The following is a description of a gene set: from publication Chen Y, Wang X (PMID 31504780) Genes predicted to be targets of miRBase v22 microRNA mmu_miR_1a_3p in miRDB v6.0 with MirTarget v4 prediction scores > 80 (high confidence targets). Mouse Gene Set: MIR_1A_3P studied in species Mus musculus, and this is the list of marker genes: Msantd2, Actb, 9230112D13Rik, Sprn, Fnip2, Arf3 (NCBI Gene Id 78763), Ccdc166, D6Wsu163e, Cnn3, Hspd1, Josd1, Eml3, Miga2, Kalrn, Fam168a, Peak1, Tpm4 (tropomyosin 4), Prlr, Lrrc8a, Hmcn1, Ywhaz, Vamp2, Pde7a, Tpm3 (NCBI Gene Id 59069), Cndp1, Rrm1, Utrn, Alkal2, Sec22b, Tmem178, Klf4, Pax3, Phax, Hycc1, Srsf9, Ankrd29 (NCBI Gene Id 225187), Glce (glucuronyl C5-epimerase), Zc3h7b, Map1a, Nfatc3, Cdk14, Ank3, Frs2, Smim14, Zfp40, Mon2, Tmcc1, Phyhip, Azin1, Ncoa1, Cask, Sec61a1, E2f5, Suz12, Rabgap1l, Ust, Cd2ap, Meox2, Lyz3, Nrp1, Smarcb1, Nxt2, Snai2, Kat6a, Zfp740, Bdnf, Kmt2e, Tmsb4x, Slc37a3, Atp6v1a, Rfesd, Xpo6, Cited2, Clock, Tnpo2, Ube4a, Wnt3, Rnf138, Kank4 (NCBI Gene Id 242553), Ubr5, Adprm, Ptpn14, Ttc7b, Slc29a3, Pax7, Sox17, Raver2, Ywhab, Gnpda2, Mex3c, Map4k3, Arap2, Helz2, Hnrnpu, Clcn3, Zfp661, Nxph2, Gclc, Serpinf1, Arf4, Ncl, Setbp1, Cap1, Sec63, Bach2, Arcn1, Cfap47, Ip6k2, Slc25a22, Jade3, Igf1 (insulin-like growth factor 1), Mctp1, Kcnd3, Foxp1, Sash1, Bsn, Zfp280d, Cav2, Ube2h, Tars2, Adgra3, Cped1, Ms4a7, 1700066M21Rik, Chsy1, Eva1a, Pip4p1, Nedd9, Mapkbp1, Ppp4r2, Adpgk, Mmd, Hacd3, Pirt, Elf1, Matr3, Col25a1, Cebpz, Ppib, Creb5, Syt1, Lasp1, Ets1, Esp34, Spred1, Mtx1, Edn1, Gja1, Ss18, Rictor, Stard7, Sema6d, Nol4l, Frmd3, Wnk3, Hmgn1, Spire1, Hipk3, Pdcd10 (programmed cell death 10), Ktn1, Ddx5, Tmem18, Man2b1, Fbxo33, Nfatc2, Rnf145, Kcnip3, Cmpk2, Mpp7, Sulf1, Sri, G6pdx, Prkacb, Pgrmc1, Atg13, Rbm27, Cdc14a, Serp1, Glcci1, Stmn2, Ndrg1, Larp4, Cdk6, Marchf1, Caap1, Ptprg, Slc39a10, Thrb, Prkce, Dgke, Tra2b, Trappc4, Wars2, Tppp, Stc2 (stanniocalcin 2), Dnajc6, Ap1s1, Ccsap, Zfp36l2 (zinc finger protein 36, C3H type-like 2), Grk6, Tnks2, Slc25a25, Twf1, Zfp800, Slc8a2, Myocd, Phf6, Srgap2, Anxa2, Pik3c2a, Tspyl4, Knop1, Ndrg3, Nexmif, Mfsd14a, Rit2, Unc119b, Sp2, Fndc3a, Ajuba, Arhgap25, Gkn2, Pla2g4a, Dlg1, Dach2, Syn3, Kif2a (NCBI Gene Id 319353), Mecom, Fn1, Git1, Glis2, Kctd10, Rnf150 (ring finger protein 150), Arfip1, Bcl11a, Plxna4, Plppr4, Smarcc1, Wbp1l, Mylk, Stk39, Tspan4, Crem, Eeig1, Nup50, Tbc1d15, Rgs19, Yipf4 (Yip1 domain family, member 4), Lrch1, Slc25a53 (solute carrier family 25, member 53), Gpr158, Timp3, Usp33, Thoc2, Pdik1l, Snx2, Folr1, Coro1c, Dennd6a, Gpd2, Cttnbp2nl, Phip, Slc38a3, Wdr48, Hmbox1, Tex2 (testis expressed gene 2), Ccr1l1, Mmd2, Scaf11, Ralgapb, Neto1, Tex11, Dach1, Trim2, Osbpl7, Obsl1, Max, Stag2, Dph6, Adar, Nlrp4e (NLR family, pyrin domain containing 4E), Entpd7, Eif1ax, Asxl3, Tbp, 4930563E22Rik, Tgfbr3, Cbl, Hsp90b1, Atxn1l, Fndc3b, Bltp3b, Thbs1, Hinfp, Tmem243, Mal2, Atf2, Hs3st3b1, Trappc3